The following is a description of a gene set: Reactome Pathway: ATF6 (ATF6-alpha) activates chaperones studied in species Homo sapiens part of: Unfolded Protein Response (UPR) ATF6-alpha is a transmembrane protein that normally resides in the Endoplasmic Reticulum (ER) membrane. Here its luminal C-terminal domain is associated with BiP, shielding 2 Golgi-targeting regions and thus keeping ATF6-alpha in the ER. Upon interaction of BiP with unfolded proteins in the ER, ATF6-alpha dissociates and transits to the Golgi where it is cleaved by the S1P and S2P proteases that reside in the Golgi, releasing the N-terminal domain of ATF6-alpha into the cytosol. After transiting to the nucleus, the N-terminal domain acts as a transcription factor to activate genes encoding chaperones., and this is the list of marker genes: MBTPS1, HSP90B1, NFYA, DDIT3, HSPA5, XBP1, NFYC (nuclear transcription factor Y subunit gamma), NFYB, ATF6, CALR, ATF4, MBTPS2